Given this list of marker genes SKP2, CCPG1 (NCBI Gene Id 9236), SPCS1, TRIM28, FAM111A, TMEM106A, PYCARD, PRKCB, ARHGAP32 (Rho GTPase activating protein 32), PDGFB, TIFAB, MRPL57, EDEM2, MCEE, PLA2G4A, MSL1, OSBPL5, HEBP1, ALOX5AP, CHIC1, MTG1, PPP1R9B, HNRNPUL2, TACO1, EFCAB9, IMP3, PDLIM2, PPIL1 (peptidylprolyl isomerase like 1), PRDX2, ARL6IP1, PARS2, PHACTR2, ALPK1, HHEX, SUDS3, WDR18, S100A6, TBC1D9, PLS3, MRPL49, BCL2L2, CTSD, CLIC1, TFPT, KCTD11, NOD1, FAM161A, HACD4, NME3, TMEM229B, ANPEP, CTSS, PPP3R2, LARGE1, FBXL8, TMEM165, GPR155, HAP1, VWA5A, DOCK5, IFIT2 (interferon induced protein with tetratricopeptide repeats 2), CD300LB, SERPINB8, NPL, PSMB8, GOLPH3L, BHLHE40, CFH, PAFAH1B3 (platelet activating factor acetylhydrolase 1b catalytic subunit 3), MX2, SLC27A4, C16orf54, KPNB1, RNF130, PCCB, RNF168, HS3ST2, SGIP1, FPR1, SCARB1, GFUS (GDP-L-fucose synthase), ABCB4, UBE2L6, WDFY4, CD81, VNN3P, UBTD1, FGD4, ASB7, SPO11, TBC1D8, GRPR, OBI1, SLC46A3, CCND1, NDUFS7, SLC41A3, SLPI, AGAP1, COL14A1, ARPC5L (NCBI Gene Id 81873), CCNG1, ADAP2, LIG4, AGK, B3GALT4 (NCBI Gene Id 87866), YY1, RAB3IL1, TPM1, SCAMP1 (secretory carrier membrane protein 1), CTBP2, DUSP7, MET, CAP1 (cyclase associated actin cytoskeleton regulatory protein 1), TMEM50A, CXCR2, MLEC, COMMD6, DOCK1, LIPA (lipase A, lysosomal acid type), AP2S1, GIGYF2, SLC8B1, PSAP, NFAM1 (NFAT activating protein with ITAM motif 1), GDPD1, SSRP1, COPS6, S1PR4, POFUT1, LRP5, SEC22C, DYNLT2B, CREBL2, MGAT1, CD48, VIM, TBC1D10C, CD300LD, EGLN1, CDH5, NMI, FNDC11, UBTF, C1QA, IQCE, TLR8, MRPL11, SULF2, NR1H3, RTCA, ELOVL1, LYPLA2, BLOC1S3, NXPE4, CASP9, CDH18, RAB31, C1QB, PTRH2, PHF11 (PHD finger protein 11), TAPBP, here is a description of the gene set: The transcription factor FoxP3 partakes dominantly in the specification and function of FoxP3+ CD4+ T regulatory cells (Tregs), but is neither strictly necessary nor sufficient to determine the characteristic Treg transcriptional signature. Computational network inference and experimental testing assessed the contribution of several other transcription factors (TFs). Enforced expression of Helios or Xbp1 elicited specific signatures, but Eos, Irf4, Satb1, Lef1 and Gata1 elicited exactly the same outcome, synergizing with FoxP3 to activate most of the Treg signature, including key TFs, and enhancing FoxP3 occupancy at its genomic targets. Conversely, the Treg signature was robust to inactivation of any single cofactor. A redundant genetic switch thus locks-in the Treg phenotype, a model which accounts for several aspects of Treg physiology, differentiation and stability. species: Homo sapiens Genes up-regulated in CD4 T conv: control versus over-expression of IRF4. from publication Fu W, Ergun A, Lu T, Hill JA, Haxhinasto S, Fassett MS, Gazit R, Adoro S, Glimcher L, Chan S, Kastner P, Rossi D, Collins JJ, Mathis D, Benoist C (PMID 22961053) Human Gene Set: GSE40274_CTRL_VS_IRF4_TRANSDUCED_ACTIVATED_CD4_TCELL_UP